Given this list of marker genes DYM, LRP1, ARSB, LAMA5, GLB1, here is a description of the gene set: Underdeveloped acetabulae. species: Homo sapiens Human Gene Set: HP_HYPOPLASTIC_ACETABULAE Hypoplastic acetabulae